The following is a description of a gene set: species: Homo sapiens Genes up-regulated by RUNX1-RUNX1T1 fusion protein in normal hematopoietic progenitors; their expression was sustained in subsequently developing granulocytes. Human Gene Set: TONKS_TARGETS_OF_RUNX1_RUNX1T1_FUSION_SUSTAINED_IN_GRANULOCYTE_UP from publication Tonks A, Pearn L, Musson M, Gilkes A, Mills KI, Burnett AK, Darley RL (PMID 17898786) The t(8;21)(q22;q22) occurs frequently in acute myelogenous leukaemia and gives rise to the transcription factor fusion protein, RUNX1-RUNX1T1 (also known as AML1-ETO). To identify the genes dysregulated by the aberrant transcriptional activity of RUNX1-RUNX1T1, we used microarrays to determine the effect of this mutation on gene expression in human progenitor cells and during subsequent development. Gene signatures of these developmental subsets were very dissimilar indicating that effects of RUNX1-RUNX1T1 are highly context dependent. We focused on gene changes associated with the granulocytic lineage and identified a clinically relevant subset of these by comparison with 235 leukaemia patient transcriptional signatures. We confirmed the overexpression of a number of significant genes (Sox4, IL-17BR, CD200 and gamma-catenin). Further, we show that overexpression of CD200 and gamma-catenin is also associated with the inv(16) abnormality which like RUNX1-RUNX1T1 disrupts core binding factor activity. We investigated the functional significance of CD200 and gamma-catenin overexpression in normal human progenitor cells. The effect of IL17 on growth was also assessed. Individually, none of these changes were sufficient to recapitulate the effects of RUNX1-RUNX1T1 on normal development. These data provide the most comprehensive and pertinent assessment of the effect of RUNX1-RUNX1T1 on gene expression and demonstrate the highly context-dependent effects of this fusion gene., and this is the list of marker genes: CYP1A1, GUCY1A1, TMEM176B, ALDH1A1, CRHBP, ID1, CD200, HSPB1, JUP, TM4SF1, ARID5B (NCBI Gene Id 84159), IL17RB, IFI16, F2RL1, SOX4